Given this list of marker genes PLK2, CD200, AVPR1A, TTC39B, EIF2B5, SEMA3A, ZC3H12A, GZMB, SAA2 (serum amyloid A2), IFRD2, SH3GL3, CCNB1IP1, ANGPT2 (NCBI Gene Id 285), SLC39A14, SDHAF1, SCT, KPNA3, IL1RN, EDN1, WWOX, WIPI2, TNIP1, NSUN4, TIMP3, TSC22D3, XDH, STAB1, MOAP1, TXNRD3, INPP5B, NMB, SLC7A2, SLC27A3, MT2A, PROCR, GRAMD4, EBNA1BP2, RFFL, BCR, CCDC137, TAX1BP1, PRPF31, RGS1 (NCBI Gene Id 5996), MAFF, PLIN2, CXCL3, NMT2, TMA16, ANXA4, BCL2L14, MERTK, TIMP1, LYVE1, IFITM3, RNPS1, OAF, CA13, PMEPA1, LOX, SPRY1, PDE4B (phosphodiesterase 4B), CX3CL1, EMP1, TNF, ADM, SBDS, DDX49, CARS1 (cysteinyl-tRNA synthetase 1), GARS1, PLAGL1, ATF3, SLC3A2, NAA15, CXCL11, CDKN1A, PUM3, DR1, UBR4, ARIH2, IL15RA, LARS1, ITGA5, BATF3, CYTH3, ADAM9, RAMP3, ALDH1A2, SCHIP1, HIF1A, PDK4, IL1A, IFI44, IL6, GBP4, INHBB, ZWINT, GADD45G, SESN1, GTF2F1, KARS1, ZC3H12C, SIN3A, CCL13, MMP20, ECE2, RAB8B, FKBP5, BATF2, CD83, SPHK1, NFE2L2, CEMIP2, CHAC1, TREX1, IFNG (interferon gamma), TGM2, RHOJ, SERPINE1, TOMM70, CXCL9, MAP3K6, ENC1, RNF115, CTTNBP2NL, GBP2, VDR, TNFRSF4, DUSP16, TNIP2, NR1I2, JDP2, CCDC86, RBMS2, MMP3, PHC1, PEX11A, TNFAIP2 (NCBI Gene Id 7127), GADD45B, STING1, F2RL3, UBALD2, UBD, ZNRF1, CD70, DUSP10, CEBPG, RND3, ODC1, UPP1, NECAP2, MBTD1, PSMA2, UBE2G1, DDIT3, SOD2, PLA1A, UBC, CCL4, TIMM8A, NOLC1, IL10, RARS1, ANXA7, MMP13, ERRFI1, ICAM1, ATP11A, EGLN2 (egl-9 family hypoxia inducible factor 2), TFPI2, SUSD2, SERPINB9, H6PD, AKAP12, LITAF, AKT3, CXCL2, PTPN22, IFRD1, NRF1, CD40, SPSB1, CCL7, ADAMTS4, CCN2, MT1E, SAV1, SOCS2 (NCBI Gene Id 8835), KPNB1, PSMA7, ADPRM, RHOB, CCR7, ITGAV, NFIL3, CP, ELP5, TRIB1, CSF3, NIBAN2 (NCBI Gene Id 64855), CDH5, here is a description of the gene set: from publication Kwon H, Thierry-Mieg D, Thierry-Mieg J, Kim HP, Oh J, Tunyaplin C, Carotta S, Donovan CE, Goldman ML, Tailor P, Ozato K, Levy DE, Nutt SL, Calame K, Leonard WJ (PMID 20064451) species: Homo sapiens Interleukin-21 (IL-21) is a pleiotropic cytokine that induces expression of transcription factor BLIMP1 (encoded by Prdm1), which regulates plasma cell differentiation and T cell homeostasis. We identified an IL-21 response element downstream of Prdm1 that binds the transcription factors STAT3 and IRF4, which are required for optimal Prdm1 expression. Genome-wide ChIP-Seq mapping of STAT3- and IRF4-binding sites showed that most regions with IL-21-induced STAT3 binding also bound IRF4 in vivo, and furthermore, revealed that the noncanonical TTCnnnTAA GAS motif critical in Prdm1 was broadly used for STAT3 binding. Comparing genome-wide expression array data to binding sites revealed that most IL-21-regulated genes were associated with combined STAT3-IRF4 sites rather than pure STAT3 sites. Correspondingly, ChIP-Seq analysis of Irf4_/_ T cells showed greatly diminished STAT3 binding after IL-21 treatment, and Irf4_/_ mice showed impaired IL- 21-induced Tfh cell differentiation in vivo. These results reveal broad cooperative gene regulation by STAT3 and IRF4. Genes up-regulated in T cells: control (0h) versus IL21 for 24h. Human Gene Set: GSE19198_CTRL_VS_IL21_TREATED_TCELL_24H_UP